The following is a description of a gene set: species: Homo sapiens Human Gene Set: VALK_AML_CLUSTER_16 from publication Valk PJ, Verhaak RG, Beijen MA, Erpelinck CA, Barjesteh van Waalwijk van Doorn-Khosrovani S, Boer JM, Beverloo HB, Moorhouse MJ, van der Spek PJ, Löwenberg B, Delwel R (PMID 15084694) Top genes from cluster 16 of acute myeloid leukemia (AML) expression profile; 81% of the samples are FAB M5 subtype, 45% have 11q23 abnormalities. BACKGROUND: In patients with acute myeloid leukemia (AML) a combination of methods must be used to classify the disease, make therapeutic decisions, and determine the prognosis. However, this combined approach provides correct therapeutic and prognostic information in only 50 percent of cases. METHODS: We determined the gene-expression profiles in samples of peripheral blood or bone marrow from 285 patients with AML using Affymetrix U133A GeneChips containing approximately 13,000 unique genes or expression-signature tags. Data analyses were carried out with Omniviz, significance analysis of microarrays, and prediction analysis of microarrays software. Statistical analyses were performed to determine the prognostic significance of cases of AML with specific molecular signatures. RESULTS: Unsupervised cluster analyses identified 16 groups of patients with AML on the basis of molecular signatures. We identified the genes that defined these clusters and determined the minimal numbers of genes needed to identify prognostically important clusters with a high degree of accuracy. The clustering was driven by the presence of chromosomal lesions (e.g., t(8;21), t(15;17), and inv(16)), particular genetic mutations (CEBPA), and abnormal oncogene expression (EVI1). We identified several novel clusters, some consisting of specimens with normal karyotypes. A unique cluster with a distinctive gene-expression signature included cases of AML with a poor treatment outcome. CONCLUSIONS: Gene-expression profiling allows a comprehensive classification of AML that includes previously identified genetically defined subgroups and a novel cluster with an adverse prognosis., and this is the list of marker genes: MBNL1, C1orf54, CLSTN2, ADD2, TRPM4, BABAM2 (BRISC and BRCA1 A complex member 2, NCBI Gene Id 9577), TKTL1, ADCY9, CADM1, CACNA2D3, KCNN2, TGM5, ITGA7, AKR7A2, CD70, ACSL4 (NCBI Gene Id 4426), XAGE1B (X antigen family member 1B), UVRAG, PENK, TDRD7, GGA2, RET, RPP25, AK2, APOC2, DACH1, CEP15, LAMP5